Given this list of marker genes GUSB, GALNS, NGLY1, HGSNAT, TRPV4, IDUA, SLC35C1, PIK3C2A, ARSK, IDS, VPS33A, SUMF1, GNS, SGSH, FUCA1, GNPTAB, GLB1, GNPTG, RMRP, NAGLU, ARSB, COL2A1, here is a description of the gene set: Excessive amounts of mucopolysaccharide in the urine. species: Homo sapiens Human Gene Set: HP_MUCOPOLYSACCHARIDURIA Mucopolysacchariduria